Given this list of marker genes Plec, Cd151, Megf6, Itgb4, Krt14, Itga6, Col17a1, Krt5, Dst, here is a description of the gene set: species: Mus musculus Type I hemidesmosome assembly Mouse Gene Set: REACTOME_TYPE_I_HEMIDESMOSOME_ASSEMBLY